The following is a description of a gene set: studied in species Homo sapiens Over curvature of the thoracic region, leading to a round back or if sever to a hump. Thoracic kyphosis Human Gene Set: HP_THORACIC_KYPHOSIS, and this is the list of marker genes: GNPTAB, FGFR3, RNF113A, KIF22, AP1G1, NFIX, PRKG2, SMARCAL1, RYR1, NEPRO, PIK3C2A, SRD5A3, POP1, CYP27A1, SLC26A2, LMNA, RMRP, ADAMTS15, MPLKIP, WDR81, GLB1, TPM2, CARS1, CDH11, EXTL3, ERCC3, MAN2B1, TRAPPC2, ERCC2 (ERCC excision repair 2, TFIIH core complex helicase subunit), ALDH3A2, LHX3, ANKRD11, COL2A1, DMD, MGAT2, AMER1, GUSB (glucuronidase beta), KY, NARS1, TARS1, CCN6, AIFM1, GTF2H5, FBXO28, NPR2, GBA1, HECTD4, VPS33A, FLNB (NCBI Gene Id 8413), TRPV4, GTF2E2, MED12L, TONSL, DYM, AARS1, LBR, PUF60, PHF8, XYLT2